The following is a description of a gene set: Familial partial lipodystrophy Human Gene Set: WP_FAMILIAL_PARTIAL_LIPODYSTROPHY species: Homo sapiens, and this is the list of marker genes: KLF9, LMNB1 (lamin B1), PNPLA2 (patatin like phospholipase domain containing 2), LMNA, BANF1, PRRX1, ICMT, AKT2, PLIN1 (NCBI Gene Id 5346), MGLL, PPARA, GATA3, GATA2 (NCBI Gene Id 84724), ZMPSTE24, KLF5, PIK3CA (NCBI Gene Id 5290), MAPK9, FNTA, CIDEC, CIDEA, FABP4, LIPE, PPARG, KLF2, SREBF1, LPL, CEBPA, LMNB2, INS, STAT5B